Given this list of marker genes ZAR1, MYD88, NBAS, IREB2, ELAVL4, TENT5A, THRAP3, QKI, RBM46, DAZ1, TENT4A, DAZ3, RBM24, E2F1, IGF2BP2, ZFP36, YBX3, IKBKE, TOB1, RBM10, HNRNPAB, HNRNPU, LARP1B, METTL16, APOBEC1, SRSF1, PAIP1, DAZ4, TENT5D, HNRNPC, PABPC1, FAM76B, PKP1 (plakophilin 1), TAF15, BOLL, MEIOC, MAPKAPK2 (MAPK activated protein kinase 2), TARDBP, METTL14, TIRAP, CSDE1 (cold shock domain containing E1), RBM47, SLC11A1, A1CF, TRAF5, ZC3H14, DAZL, YBX1, RBM38, DAZ2, MAPK14, EIF4ENIF1, NRDE2, HNRNPA0 (heterogeneous nuclear ribonucleoprotein A0), ARID5A, TENT5B (terminal nucleotidyltransferase 5B), CIRBP, DHX9, NICOL1, DND1, PKP3 (plakophilin 3), SECISBP2, NOCT, ANGEL2, IGF2BP3, UPF3A (UPF3A regulator of nonsense mediated mRNA decay), VIP, TRAF3IP2 (NCBI Gene Id 25997), GDNF, IGF2BP1, TRAF2, HNRNPD, DHX34, TENT5C (terminal nucleotidyltransferase 5C), AXIN2, LARP4B, TENT4B, FXR1, ELAVL1, FBLL1, LARP1, SYNCRIP, FUS, here is a description of the gene set: Any process that stops, prevents or reduces the frequency, rate or extent of mRNA catabolic process. Human Gene Set: GOBP_NEGATIVE_REGULATION_OF_MRNA_CATABOLIC_PROCESS studied in species Homo sapiens